The following is a description of a gene set: studied in species Homo sapiens Human Gene Set: REACTOME_VEGFR2_MEDIATED_CELL_PROLIFERATION VEGFR2 mediated cell proliferation, and this is the list of marker genes: ITPR3, PRKCD, AHCYL1, KRAS, SRC, PRKCA (NCBI Gene Id 5578), CALM1, PDPK1, ITPR1, PRKCZ, HRAS, VEGFA, PRKCB, SPHK1 (sphingosine kinase 1), PLCG1, NRAS, KDR, RASA1, ITPR2